Given this list of marker genes SLC26A5, NDNF, PER2, SLC8A2, PANX1, MAP2K3, PANX2 (pannexin 2), SIRT5, SOS1, PIK3CB, MLYCD, NPR3, STUB1, MIR195, HYOU1, GPR31, EGR1, CASR, PINK1, P2RX4, AIFM1, CX3CL1, RNLS, TREM2, CSF1R, GPR151, KCNJ8, HK2, MAP3K5, FAIM2, SQSTM1, ABRAXAS2, CSF1, RCAN1, CIB1, STAT3, REST, CAV3 (caveolin 3), EEF2, CX3CR1, EEF2K, CAMK2A, NOL3, P2RX7, CPEB4, MEF2C, BCL2, NFE2L2 (NCBI Gene Id 4780), CAV1, ROCK2, UCHL1, TP53, CASP9, AQP3, NPPC (NCBI Gene Id 4880), RELA, PPIF, TIGAR, ITGAM, BVES, P2RX2, KCNJ11, MYB, here is a description of the gene set: studied in species Homo sapiens Any process that results in a change in state or activity of an organism (in terms of movement, secretion, enzyme production, gene expression, etc.) as a result of a inadequate blood supply. Human Gene Set: GOBP_RESPONSE_TO_ISCHEMIA